The following is a description of a gene set: A rapid heartrate that exceeds the range of the normal resting heartrate for age. studied in species Homo sapiens Human Gene Set: HP_TACHYCARDIA Tachycardia, and this is the list of marker genes: PKP2, CACNA1C, GPD1L, TRDN, RYR2, SCN3B, MYRF, PRDX1, SCN10A, SDHC, MAX, SRY, ASXL1, ZNF699 (zinc finger protein 699), FMO3, KIT, CSF2RA, CRELD1, FBXL4, UCP2, ACADVL, RET, CDH2, SEMA3A, JUP, MYL2, GATA6, COX7B, ABCC9, CRYAB, THRB, RHAG, GYG1, NUP155, SDHD, FLAD1, NDUFB11, KCNJ8, PPP1R13L, TET2, BAG5, CAP2, NAXD, PRNP, MYZAP, CALM2, VHL, KCNE3, RANGRF, LAMP2 (lysosomal associated membrane protein 2), BMP2, DSG2, JPH2, SDHB, TTN, TPM1, ECE1, CPT2, MYH6, MT-CYB, MYH7, SLC25A20, RHCE, SCNN1A, DNMT3A, NKX2-6, HLA-DRB1, SCN9A, ELP1, HCN4, SLC12A3, KCNJ5, HMBS, KCTD1, PLXND1, SPRED1, TSHR (NCBI Gene Id 7253), CALM3, MMACHC, TNNI3K, PYGM, CUBN, VPS33A, LMNA, GATA4, GNAI2 (G protein subunit alpha i2), KCNJ2, TRPM4, CTNNA3, ACTN2, SCN2B, KCNJ11, TLL1, CNBP, DST, PPOX, SLC19A2, LMOD2, SCN1B, CSRP3, CASQ2, TBX5, PGM1, TBX1, ABCA3, SRSF2, ABCC8, CACNA2D1, SCN5A, KCNJ18, HCCS, TANGO2, NAA10, FBP1, KYNU, AMN, BTNL2, SFTPC, HNF1A, CPOX, CALM1, CACNB2, CITED2, RYR1, CACNA1S, TMEM43, SFTPB, CAVIN1, KCNE5, CSF2RB, KCND3, AKAP9, DSP, MYOZ2, TBX20, PRORP, TMEM127, HNF4A, NPPA, TECRL, ACTC1, SLMAP, RHD, NKX2-5